Given this list of marker genes CD1C, FAM89A (NCBI Gene Id 375061), SLC4A7, ARHGAP11A, CNOT6L (NCBI Gene Id 91275), SPOPL, APPBP2, FAM47E, ERBB4, CANX, GNG12, LRP8, BRWD3, CRBN, FEM1C, ZNF770, SYNJ1, RFC3, NUP160, CPNE1, TRIP11, ABCC9, SYT14, LRP1B, ACVR1C, EMB, RNF146, RPGRIP1L, SMAD4, MEX3D, UBASH3B, FBXO25, RAP1B, CSF2RB, PRKG1, CAPZA1, ZMIZ1, LACTB2, BNIP3, STK39, RRM2B, NEGR1, PPEF2, SNX16, XKR9, GNA14, PTPN2, KGD4, LIPF, MOB4, GAS7, SPACA1, CCDC80, DUXA, VAV3, ITGB8, FAM120A, TAB1, RUBCNL, MTCP1, SPC25, SEMA3D, ICA1L, SLC25A36, LHFPL3, CARF, KLF3, VPS54, ZCCHC2, TRIOBP, SP1, SLC35D1, MTHFD2, MTNAP1, C5orf24, ZBTB33, CCP110, ANGPTL5, N4BP2, FNDC3B, DCUN1D5, PPP6C, TBL1XR1, ELAVL4, MBOAT2, SOCS6, KCNG3, STEAP2, RAP1A, ZNG1A, USP12, LSM8, TRMT13, SPCS3, ZDHHC20, BMI1, FOXC1, SLC15A5, ACVR2A, S1PR1, CEP120, ACYP2 (acylphosphatase 2), NFIA, HTR2C, ZNG1E, AAK1, PCDH15, SLAIN1, ASCL1, KCNIP4, PLET1 (NCBI Gene Id 349633), FOXF2, RHOQ, DOCK4, GOLPH3L, FAM91A1, RPS6KA3, IGSF11, ZNG1C, TBC1D8B, SLC24A3, COL6A3, PDCD6IP, ZBTB10, WDR11, PIK3C2A, NUFIP1, NR1I2, USP38, ZNF567, LIX1L, RWDD4 (NCBI Gene Id 201965), TET2, RPS6KA5, PHIP, DCUN1D4, ZKSCAN3, FGD6, NCKAP1, GPR155, RRAS2, IGF2BP3, GPCPD1, UBE2A, GRIP1, CPNE4, HLTF, CEP350, TAFA1, ESR1, DLG2, DDTL, STXBP5L, SMG1, DIAPH2, ABHD13, LRRC70, ADAM17, PPARGC1B, CCNY, BPNT2, PPIC, F3, MBLAC2, MDGA2, ABCB5, INPP5A, TLK1, SCAI, PDE12, MAPK6, SFT2D1, NLGN1, HECA, FBXL5, NFKB1, AKAP11, FAM24B, CNEP1R1, SLC6A15, CDC42BPA, MAP3K2, MYO5A, PDK1, TMEM30A, RAB21, ENTPD1, PTPN13, TMTC1, AGFG1, ZNF257, PBRM1, BOLL, SLC9A4, KCNA1, RSBN1, ZBTB41 (NCBI Gene Id 360023), TMEM100, QKI, MTPN, CAPRIN1, APPL1, ZEB2, SELENOT, DCLK1, PGM2, TUBB1, OTUD1, CCSER1, PROM1, IRAK1BP1 (NCBI Gene Id 80793), CXCL3, BRCA2 (NCBI Gene Id 82716), PLEKHG1, ZNF624, NUP37, CCDC179, TLR2, DYNC1I2, CRIPT, CPNE8, NUP133, NDC1, CD28, ANKRD44, SS18, DYNLT1, UFL1, SCML2, SLC9A2, SPRED1, CNTN1, CBR4, PDZD8, TMEM170B, LRRC59, PTGES3L, KICS2, HSPE1-MOB4, LIMS1, SETD7, ZNG1B, SACS, DENND1B, MBD2, SMAD5, GPM6A, ZNF107, ZNF493, SPRYD7, NBEA, ADCYAP1, ZBTB5, KLF10, TBR1, IPMK, MYSM1 (Myb like, SWIRM and MPN domains 1), MYCN, PPM1A, ZXDC, TBCA, MCMDC2 (minichromosome maintenance domain containing 2), ERO1B, SLC23A2, KCTD5, HOOK1, PCDHB16, GOPC (NCBI Gene Id 57120), IST1, COL4A4, PGGT1B, EXOC5, PURB, AQP11, PRKAR2A, ACSL6, HOOK3, ZNF660, CYP8B1, GCNT2, FIGN, TLCD4, BBX, FZD3, KLF8, PRKAA2, DUS4L (dihydrouridine synthase 4 like), MTF1 (NCBI Gene Id 4520), ABCG2, RORA, ANKRD12, POLR3G, CEP97 (centrosomal protein 97), LHFPL5, NCAM1, ATL3, ZNF470, NUDT11, ADAMTS1, ZSCAN12, RP2, VGLL3, ZNF705EP, PLEKHJ1, COMMD3-BMI1, SMIM15, CCDC141, KITLG, NFAT5, SEC61A2, CREBZF, ZFAND1, PSAT1, STXBP5, EPC2, NEK1, SRSF6, MEGF11, HIVEP2 (NCBI Gene Id 3097), UBE3D, EYS, SAXO2, RNF138, MAST4, ATP8A1, PIK3CA, PPHLN1, ZBTB20, AADAC, COX20, GASK1B, ANKRD22, PPP4R2, ERO1A, MAP9, SH3RF1, PKN2, PDZRN4, ATG16L1, ACTR3, ARL13B (ADP ribosylation factor like GTPase 13B), ARHGEF3 (Rho guanine nucleotide exchange factor 3), USP44, NENF, SLC25A21, SKI, PDLIM5, PRDM11, WAPL, SNTG1, ZNG1F, SENP1, MSI2, CSNK1D (casein kinase 1 delta), OTUD4, E2F4, PIBF1, CHD9 (NCBI Gene Id 80205), NQO1, KIF18A, SPO11 (SPO11 initiator of meiotic double strand breaks), TAF2, SLC30A4, IL20RA, EDDM3B, MAP3K20, here is a description of the gene set: Genes predicted to be targets of miRBase v22 microRNA hsa-miR-548l in miRDB v6.0 with MirTarget v4 prediction scores > 80 (high confidence targets). Human Gene Set: MIR548L species: Homo sapiens from publication Chen Y, Wang X (PMID 31504780)